Given this list of marker genes GCAT, LHX2, RPN1, DUSP3, RNF113A, SQSTM1, TNFSF9, CREBZF, MCM5, EIF4EBP1, SCO2, HLA-G, IDH2 (NCBI Gene Id 3418), SLC30A3, TUBB2A (NCBI Gene Id 92919), MAZ, HYAL2, HHEX, PMAIP1, ZNF263, PGF, E2F1, TOB1, PLD3, DAXX, HOXD9, SMARCD3 (NCBI Gene Id 6604), CSRNP2, ERGIC3, CDT1, TREX1, NME3, PCDH9, ADO, TMX4, PLEKHO2, SIX1, STK25, PSMD8, MGAT1, GBA1LP, TRIM25, TPM2, CASP3, NDUFS7, ABCB6, AP3M2, STX16, CCDC85B, PSMC3, PNRC1, CTSV, CCNG2, SHOX2, FEN1 (NCBI Gene Id 5882), PLCB3, AP2S1, MFAP3, ATP6V1F, FLNA, CDK2, TMED1, PLXNA3 (plexin A3), SULT1A2, MBD4, GAS1, TK1, PKMYT1, SNHG29, RFC5, GRINA (glutamate ionotropic receptor NMDA type subunit associated protein 1), HSPA2, PHLDA2, CCNE1, TPBG (trophoblast glycoprotein), GNL1, MED6, THAP3, SHMT1, YKT6, RHOB, NPRL2, NCBP2, CA5BP1, GSTT2, BTBD2, CDKN2C, PIM2, MRPL23, SAC3D1, ACYP1, HSPA1A, EEF1D, EIF3I, CNP, HNRNPU, RPUSD2, UQCRC1, ALDH1B1, PDAP1, ABCF3, PTPN11, PSMC3IP, RELA, CREG1, FAM8A1, GALNT2, FADS1, OAZ2, CZIB, ATF3, JUNB, BOLA2, ASL, ACOT2, RNF40, KLHDC3, MLLT11, NFE2L1, RBM4, PRPF4, MICB, LY6E, CDC6, TRIM21, RBM38 (RNA binding motif protein 38), BTG2, PSMB10, ABHD14A, KCNJ4, RGS2, ERCC2, SNRPA, NSUN5P1, CCNE2, GLUL, TNFRSF10D, HEXIM2-AS1, MOAP1, TEX30, EPOR, TBCC, SIGMAR1, TST, OGG1, GCH1, RAD9A, PER2, RPS15A, U2AF2, IRF1, ISG15, MBOAT7, PDLIM7, RSL1D1, EIF2S3, MCM4, HLA-A, PLTP, SYNM (synemin), SPR, TCIRG1, PQBP1, GABARAPL1, RPS6KB2, RNF103, CCND3, ZNF510, GATD3, CDKN1C, ADA, SMIM10L1, ZKSCAN1, TYK2, ERCC1, MEA1, CDKN2B, NFKBIE, LIN37, EFNA1, CYP1B1, BAD, DGAT1, BTG1, TNFSF13, PAFAH1B3, PPIE, CDC34, NCDN, NDUFV1, CBX2, DMPK, ICAM3, OGFR, NPTXR, ENSG00000275616, RSRP1, PLPBP, TM7SF2, EWSR1, TRIAP1, S100A13, CYB5B, RAB8A, BAK1 (BCL2 antagonist/killer 1), PPIF, PITX2, THBS1, AMACR, TUBA4A, IFITM2, TFAM, TYMS, SERPINH1, CREM, NEU1, CDO1, MRPS12, NDUFB7, CBR3, FKBP1A (NCBI Gene Id 2280), SLC6A8, FRAT2, TERF2, BAG1 (NCBI Gene Id 573), CLK3, SLC1A5, IGFBP6, C2CD2L, EPHX1, SMPDL3A, BSG, SELENOW, ECI1, HEXIM1, MYBL2, ZFPL1, BUD23, ZNHIT1, HLA-F, FGFR3, SDF2, RPL23, IFI30, PCNA, NR4A1, TP53I3, MAT2A, RABAC1, AAMP, NXF1, UBA1, ITM2B, PNP, SAT1, SAP18, GET3 (guided entry of tail-anchored proteins factor 3, ATPase), GPRC5B, TMBIM6, CEBPD, ESS2, NCLN, DDT, PPP1CA, GSTT1, CLCN2, MVD (NCBI Gene Id 4597), CYB5R1, GRHPR, PAQR4, CLK1, CTH, SMPD1, LMF2, ACAA1, HLA-E, FDXR (ferredoxin reductase), ALDOA, IL11RA, POLR2A, BRMS1, UROD, NOP2, HLA-J, OSR2, BRD2, SHMT2, SLC25A4, CLTB, GSTP1, NAT1, PVR, MPDU1, CBX4, ALAS1, ERBB2, PDCL, TSPYL2, ARRB2, GLUD1, IFIT1, ZNF330, ARPC4, DNASE2, MRPL28, PPP2R5D, TMEM109, MDK, GLS, TRIM13, UROS, CDK16, AGPAT2, CEP68, GAGE1, HAUS3, RFC2, TP53, GDI2, here is a description of the gene set: Genes up-regulated in fibroblasts expressing mutant forms of ERCC3 after UV irradiation. Xeroderma pigmentosum (XP) and trichothiodystrophy (TTD) syndromes are characterized by deficiency in nucleotide excision repair pathway, but with distinguished clinical manifestations. While XP patients exhibit a high frequency of skin cancer, TTD patients are not cancer prone. The relation between lack of DNA repair and their clinical manifestations was investigated through analysis of the transcriptional profile of 12,600 transcripts in two isogenic cell lines with different capabilities of DNA repair. These cell lines result from a stable transfection of the XPB-TTD allele into XP complementation group B fibroblasts, from an XP patient who also have clinical abnormalities corresponding to Cockayne's syndrome (CS). The microarray assays performed under normal growth conditions showed the expression of distinct groups of genes in each cell line. The UVC-transcription modulation of these cells revealed the changes in 869 transcripts. Some of these transcripts had similar modulation pattern in both cells, although with eventually different time patterns for induction or repression. However, some different 'UVC signature' for each cell line was also found, that is, transcripts that were specifically UV regulated depending on the DNA repair status of the cell. These results provide a detailed portrait of expression profiles that may potentially unravel the causes of the different phenotypes of XP/CS and TTD patients. Human Gene Set: DACOSTA_UV_RESPONSE_VIA_ERCC3_UP from publication da Costa RM, Riou L, Paquola A, Menck CF, Sarasin A (PMID 15608684) species: Homo sapiens